Given this list of marker genes HACD1, FLT3, PBK, IRF7 (NCBI Gene Id 3665), PTPA, VKORC1, NDRG1, ANAPC5, CDH1, POLD3, FNBP1L, INCENP, PCLAF, FRMD4B, DYNLL1, SMPDL3A, DPP7, CENPT, DMWD, SERINC3, MKI67, SEC61A1, PPP2R5A, KLRK1, MIER3, CENPE, FGFR1, TOP2A, MCM7, SMIM5, SSBP2, FAM117A, GRK6, ARL6IP4, POLD1, CKS1B, CDCA5, ANLN, CCDC89, ARHGAP22, KIF4A, CYSLTR1, CDC45, CCR5, FOXRED2, CENPM, KIFC1, RPL28, SGO2, ITPK1, TMEM106C, SPN, SLFN5, INTS3, ZBP1, OAS1, LRATD2, NAPRT, KEAP1, BCS1L (NCBI Gene Id 7856), C16orf54 (chromosome 16 open reading frame 54), GPR146, KNOP1, RFC2, FCHO1, SYNDIG1L, TSPO, HIRIP3, NRP1, DYNC1H1, DPYSL2, CDT1, GAS2L3, HLA-C, KCTD14, ARHGAP21, SLC5A10, SPAG5, MAP4K4, NSD2, CDKN2D, PKMYT1, SMPX, FKBP4, IMPA2, NCAPH, CKAP4, ADORA2B, FANCI, PCSK6, SRGAP2, IFITM3, ASXL1, L1CAM, BRD3, KNTC1, CDC7, HES6, TRIM28 (NCBI Gene Id 96054), P2RY6, OAS2, LMF2 (NCBI Gene Id 91289), ANXA2, RRM2, VCL, SHCBP1, DEAF1, DEPDC1B, LY6E, RNF213, ALOX5AP, LIG1, BUB1B, REPS1, VIM, CENPP, POLR1A, IQGAP2, PIF1, CKB, ZWILCH, PLEC, C19orf38, INTS4, SYS1, GARRE1, COL23A1, PRR11, CUTA, CDCA4, SBK1, WDHD1, NELFA, ARHGEF18, SLC25A10, RFTN2, ERCC6L (NCBI Gene Id 54821), NEURL1B, ALDH2, H2BC3, CCL25, SPP1, LARP4B, FRMD4A, JDP2, DAPK1, MAST2 (NCBI Gene Id 23139), TXNDC16, PRIM1, NLRC5, QPRT (quinolinate phosphoribosyltransferase), CEP152, SPTBN1, PLP2, BRCA1, SAE1 (SUMO1 activating enzyme subunit 1), XDH, TRIM25, SDC3, KCNE3, TPCN1, KIF23, STMN1, SNX1, STAG3, SLC27A2 (NCBI Gene Id 8523), CKS2, FXYD5, HIP1R (NCBI Gene Id 9026), KIF22, LGALS1, CDCA8, KRTCAP2, NCAPD2, PSRC1, SLC43A2, TEX261, IFI44, IRF4 (interferon regulatory factor 4), RAD51C, ACADL, ACSS1, HLA-B, ITGB7, TRIP13, E2F8, SUN2, OASL, CENPF, KMT5C, PRKCSH (NCBI Gene Id 5589), CDC25B (cell division cycle 25B), ELMO2, TIAM1, CXCR3, ATP10A, TTLL12 (NCBI Gene Id 23170), SMC4, CEP192, KIF11, here is a description of the gene set: species: Homo sapiens Type I Interferons encompasses a large family of closely related cytokines comprising of at least 13 IFN-α isotypes and single IFN-β. Both IFN-α and IFN-β exert their activity through a common receptor IFNAR. Type I Interferons have broad regulatory effects and various subtypes of dendritic cells are influenced by this cytokines. In our study we asked question whether the low, constitutive levels of type I Interferons produced under steady state conditions are important for proper function of splenic conventional dendritic cells. Human Gene Set: GSE12392_CD8A_POS_VS_NEG_SPLEEN_DC_DN Genes down-regulated in wildtype splenic dendritic cells: CD8A+ versus CD8A-. from publication Zietara N, Łyszkiewicz M, Gekara N, Puchałka J, Dos Santos VA, Hunt CR, Pandita TK, Lienenklaus S, Weiss S (PMID 19581626)